Given this list of marker genes SFTPA2, ARRB1, ADARB2, CUL3, ARID3B, ETV3L, LIMK2, STX1A, CARMIL3, ARHGAP19, B3GNT7, TSPAN18, SDC3, GALNT1, ATN1 (NCBI Gene Id 1822), ATF6B, ALX4, VEGFA, FBXO41, GABPB1, BTRC, ITGA10, MRPS23, TPCN1, SLC39A1, BBS1, MDGA2, MTF1, NPTX1, SESN3, CNTNAP1, RIMS3, MMP15, DNAJC13, TCF7, NACC1, ZC3H4, TOR4A, UBQLN1, PRX, PLEKHG4B, ALS2CL, STK4, EPHB3 (NCBI Gene Id 2049), SPR, SCAMP4, TGFBR1, SOX10, BOK (NCBI Gene Id 84558), PIP5K1C, APBA1, SESN1, DNAI1, IFT70B, BMF, TBC1D16, BMP1, BTG2, DRAXIN, LASP1, ARHGAP33, SH3PXD2A, PTPRT, PLXNA4, GFAP, IQSEC3, ITGA5, PTPRE, USH1G, NFASC, KDM4E, MBD6, NFAM1, HIPK1, SCUBE1, AGAP1, LHFPL4, GNAO1, NALF2, PAX7, TSEN15, SLC16A2, ULK2, PPP1R17, RAB5B, CASTOR2, SUSD2, STRN4, DISC1, MBTD1, DRG2, CLDN9, SEPTIN4, TTYH3, SORBS3, RBFOX3, DKK3, GLIS2, GLYR1, TNRC18, CPLX2, KPNA6, FGFR2, NFIC, RIN3, ATG7, FAM131B (family with sequence similarity 131 member B), CCDC169, KCNE4, SPRY4, BSN, SLC26A9, RGS6, SIPA1L1, ZNF282, MAU2 (MAU2 sister chromatid cohesion factor), SLC6A3, TMEM127 (NCBI Gene Id 84178), UBE2Q1, THBS3, STC1 (NCBI Gene Id 82914), NECTIN1, MAPKAPK2, SNX32, RNF216, NXF1, DLGAP3, FAM53C, KCNH4, RPS6KA1, CELF5, CRTC1, TP73, NOS1, FOXJ1, PITPNM2, PSMF1, CPNE2, NTSR1 (neurotensin receptor 1), SHISA6 (shisa family member 6), PPARD, FXYD6, ATXN7L3, SHISA7, ZBTB7A, LZTS1, SPMIP8, IGFBP5, CERS1, CACNB1, JRK, BACE1, KDR, RALY, NETO1, FBXL16, FAM168A, ELMO2, COL6A2, TIMM10B, BPIFC, KIF1A, NCOA5, RAB11FIP5 (NCBI Gene Id 26056, RAB11 family interacting protein 5), ATG9A, SLC38A9, AMMECR1, RARA, GSPT1, SNURF, ZNF496, POLM, DNAL4, GRIK3, MTCL2, DCTN5, CERS2, ARHGEF11, EGFR, PUS10, SYNGAP1, CLIP3, PARP6, C1orf116, ANGEL1, IPO7, CYB5RL, here is a description of the gene set: Human Gene Set: MIR6852_5P from publication Chen Y, Wang X (PMID 31504780) Genes predicted to be targets of miRBase v22 microRNA hsa-miR-6852-5p in miRDB v6.0 with MirTarget v4 prediction scores > 80 (high confidence targets). species: Homo sapiens